The following is a description of a gene set: from publication He P, Lim K, Sun D, Pett JP, Jeng Q, Polanski K, Dong Z, Bolt L, Richardson L, Mamanova L, Dabrowska M, Wilbrey-Clark A, Madissoon E, Tuong ZK, Dann E, Suo C, Goh I, Yoshida M, Nikolić MZ, Janes SM, He X, Barker RA, Teichmann SA, Marioni JC, Meyer KB, Rawlins EL (PMID 36493756) Human Gene Set: HE_LIM_SUN_FETAL_LUNG_C5_CD5_POS_CCL22_POS_MATURE_B_CELL studied in species Homo sapiens CD5+ CCL22+ mature B, and this is the list of marker genes: RGS1, EML2, SCO2 (synthesis of cytochrome C oxidase 2), CASP3, MPEG1, NENF, LINC00926, ZBTB17, NUP37, ATP2A2, EMC1, CR2, ARMCX6, BSPRY, RASA4B, ILRUN, HUWE1, NAGK, CHKB, TNFRSF18, RSU1, QPCT, STAP1 (signal transducing adaptor family member 1), PFAS, PTGER4, CNR2, IFRD2, ZMYND11, VOPP1, ATP1A1, SH2B2, TNFRSF13C, COMTD1, PTGES2, TOR3A, AGPAT3, TRAF2, CENPH, PRKCD, BIN2, TRMT1, GPX7, STK38L, BCAR3, TOM1, GNL3, ORMDL2, TNFRSF13B, MRPL17, CXCR5, PNO1, RHEX, GRK3, GPATCH4, EHD4, MRPL27, PABPC4, ICMT, ABI3, RNF126, TOP6BL (NCBI Gene Id 79703), CARM1, NFKB2, CMSS1, C1orf50, TYMP, MTHFD2, IL2RG, FADD, PHF19, SLC37A1, KLF13, ANKRD26, BMP2K, GEN1, BOLA2, ABCF3, PAGR1, SLC29A1, TRAC, HSD17B4, PAPSS1, VARS2, CD44, DESI1, ARF3, BATF, RAB30, AGL, ADISSP (NCBI Gene Id 54976), ADAM19, MSMO1, NPM3, TPTEP2-CSNK1E, JOSD2, DCPS, ACADS, UROS, ARHGAP18, TLR10, MYO5A, NPIPB4 (NCBI Gene Id 440345), PCNX1, COL9A2, PAK1IP1, ASCC3, HILPDA, GNL2, MTLN, BLVRB, DEGS1, IFI30, HSDL2, NTHL1, BCAT2, ALDH18A1, ZYX, TFEB, PRKAR1B, GTF2H5, DPH6, RPP25, CALU, TRAPPC5, TIMMDC1, TBL2 (NCBI Gene Id 27203), LINC01857, S100A6, CD82, HDAC3, PPM1M, ENTPD1, CHMP4A, NXPE3, MRPL1, DIPK1A, WDR75, ST3GAL2, PARVB (parvin beta), POLR1C, CDKN2A, FAM162A, TRBC1, NUDT14, MCRIP2, ZCRB1, NET1, IL21R, NFKBIE, ALDH3A2 (aldehyde dehydrogenase 3 family member A2), LASP1, COPRS, SEL1L3, PPP1R9B, NCLN, GMDS, TXLNG, MTAP, ACY1, PLAGL1, MAP3K8, SGK1, RRP9, PDLIM7, HCST, JAZF1, HSPBP1, SMIM30, MS4A6A, MECR, AEN, RPA1, ADGRG5, ATIC, CCL4, CCND2, LTA, FH, SFXN4, SRD5A1, NANS, PELI1 (NCBI Gene Id 57334), ZNF490 (NCBI Gene Id 57474), CASP1, PIAS2, BIK, BCL2L11, ETFB, GNPTAB, CHID1, NDFIP1, WDR89, SRM, BRI3BP, CCR7 (NCBI Gene Id 1236), TMEM35B, TRAF3 (NCBI Gene Id 7187), ERG28, PTPN7, CHKA, LACTB2, C1GALT1C1, EEIG1, ITPK1, THEM4, AP1S3, SDHAF3, SH3BP1, NOPCHAP1, ICAM1, TARBP2, BCL2A1, NAPSA, TMEM42, NOP2, MPDU1, PMM2, UQCC2, RILPL2, PNOC, DSE, BHLHE40, HSD17B8, PAWR, NBPF10, MYO1E, SH3YL1, DPH5, TYW3, ETF1, MCM6, CDK4, ITGB7 (integrin subunit beta 7), COMMD10 (NCBI Gene Id 55955), INSIG1, PCBD1, ABCE1, SLC35B2, ERCC4, AMPD3, ECE1, CCDC88C, LMAN1, KBTBD8, SNX18, IL27RA, GMFB, MIR155HG, LINC01480, PDCL3, ADAM8, SLC30A7, TBC1D9B, MRPS25, CTSH, WDFY1, LINC00996, SAMSN1, EHD1, NT5DC1, RGCC, APOBEC3F, IMMP2L, DERL1, ZNF593, CKLF, SEC24D, PLGRKT, APOBEC3G, MCOLN2, ZNF480, EBNA1BP2, CLEC17A, BCL2, RMND1, FAM81A, IFNLR1, RAB8B, FBXO4, POLD2, CD5, WARS1, NUP210, KAT2A, TRADD, TXLNA, MAPKAPK2, KPTN, NFATC1, PDCD4-AS1, FCRL2, ADPRH, PRDX4, CBFA2T3, TUBG1, DENND5B, CD68, CYBB, RELB, MED23, CDC42EP3, EEF2K, BLTP1, ST14, MYBBP1A (MYB binding protein 1a), PHPT1, RGS10, TBC1D8, WASHC3, MTX1, IFNGR1, NCOA1, RNF121, NOLC1, NUDT4, RASSF2, IGF2BP3, MMAB (NCBI Gene Id 89909), SHISAL2A, SRGN, IGFLR1, LONRF1, PHTF1, SMIM27, POLR1E, RASSF5, GLS, PDPK1, DALRD3, MYC, ALKBH6, ARHGAP1, CHMP7, S100A11, BID, MPI, EYA3, LTBP3, TRUB2, NAGPA, DPH2 (diphthamide biosynthesis 2), CYTOR, CREB3L2, IGHG1 (immunoglobulin heavy constant gamma 1 (G1m marker)), PPCDC, CCL3, SFI1, TSEN15, NUP205, TADA1, INPP5B, NFKB1, TNFRSF10A, ARL4C, RAB11FIP1, FAM136A, PEX10, NR4A3, TP53I11, KNOP1, C15orf39, NAMPT, SLAMF7, KATNA1, INTS9, FLNA, SYNE2, MCM2, TICAM1, MTERF4, ZNF688, GMPPA, STAT1, PFKP, SUPT5H, RECQL5, IGHG2, NUDT2, PYCR3, ACAT1, WNT10A, SNX25, CCR10, MRPL35, LARP4B, DHRS13, TESPA1, FKBP5 (NCBI Gene Id 2289), ITGAL, KCNAB2, MRPS12, SMS, NME1, PTPN12, HMBS, ENTR1, MAP3K14, PCCB, IRF5, WAPL, GPR65, RRBP1, TFRC, BRIX1, ANAPC1, SESN3, SNRNP25, DENND1C, QDPR, TENT5C, ACOX3, ATP6V1C2, ETV6, FUNDC1, KDM2A, RUNX3, SNAPC2 (small nuclear RNA activating complex polypeptide 2), MOGS, NICOL1, PELP1, RRP1, ZNF589, GCHFR, SLC12A2-DT, KYNU, NDUFAF8, IL10RA, ANXA7, LRRK2, DNPH1, SEMA7A, GCA, CCL4L2, ZNFX1, LPIN1, IMPACT, PLEK, CCDC28B (coiled-coil domain containing 28B), TRAP1, POGLUT1, KLHL12, SLC1A4, GCN1, NIBAN1 (NCBI Gene Id 63911), CTSZ, CRYM, NFKBIZ, CISD2, PHLDB3, PAICS, TTC31, CRYZ, SLC25A19, PLEKHO1, POLR3E, RAB29, RBM47, DYRK4, PUM3, DOK2, NAB2, SLC25A13, KLF4, DPP3, GBA1, TRMT61A, CD1D, TBC1D9, MIF4GD, OGT, PKIG, PMPCA, SLC25A45, POLR1F, CEPT1, LILRB4, PLK3, EBI3, ARPC4, DOHH, CD58, TESC, CINP, VARS1, ZNF7, IL6R, GLT8D1, MRTO4 (NCBI Gene Id 94394), TMEM14A, CHD3, MCCC2, RARA, EXOSC7, ARHGAP9, MRPL24, MDN1, NLE1, U2AF1L4, ECPAS, CCL22, ABCA6, DTNB, HEATR5B, TYK2, TCTN3 (NCBI Gene Id 26123), SLC5A6, CEBPB, MRPL11, TOP1MT, TMEM154, GGA1, ALKBH2, QTRT1, GNPDA1, SLC7A7, CTU2, CFLAR, RPIA, ECHDC2, DCTD, RHOF, SNX9, CFAP97, GM2A, TOLLIP, SERPINB9, ADTRP, SEC11C, S100A13 (NCBI Gene Id 6284), NEDD9, WDR43, CUL4B, CDIP1, WAC-AS1, AFTPH, EIF4G1, SREBF2, IVD, TTN, RASA4, JADE2, SNX8, TCIRG1, NFAT5, DUS2, LCK, HDAC9, MPHOSPH6, JAK2, MATK, CCDC86, COMMD1, POC1B, AKNA, ZDHHC12, CLECL1P, ZC3H12A, FBXW8, CTSC, PASK, EXOSC4, ELP3, ARHGAP24, NIPSNAP1, NOP16, S100A4, IFI27L2, BOP1, MYO3A, KCNN4, METTL8, MTFP1, UQCC5, C17orf49, NUFIP1, ALG2, MAPK13, HMOX2, DUSP23, DLD, XPNPEP3, ATG4C, GSTZ1, OMA1, UNG, LGMN, ACP5 (acid phosphatase 5, tartrate resistant), TSR3, UGCG, HPS5, CD1C, TGFB1, ADAMTS6, CISD1, POLD3, FCRL5, ORAI1, NOC3L, SPOPL, NCOA7, PDCD11, SEH1L, PDLIM2, ISOC2, RFTN1, LCMT1, UTP4, DHRS4, BOLA3, ZNF880, CCDC141, SCYL2, WDR4, MRPL15, ENOSF1, SIGLEC10, GBF1, ABHD6, PPP2R5A, STAMBPL1, OTUD5, EVI2A, MRNIP, PTPN22, NCOR2, RRAS2, ELF4, APOBEC3C, SPATA20, PNPLA6, FMNL3, C12orf42, GGCT, RNASE6, CCDC47, MDFIC, P2RY14, CD27, PCK2, IGHG3, PARN, RHPN1, SNX11, NRG4, SIGMAR1, TNFAIP8L1, ELK1, LPCAT1, RRP15, ZNF827 (zinc finger protein 827), SKAP1, GNG8, RHOC, POLR3K, SNX10, HTT, MVP, SLX9, S100A10 (NCBI Gene Id 6281), HDHD5, PRKD3 (NCBI Gene Id 23683), CMTM3 (CKLF like MARVEL transmembrane domain containing 3), TANK, SUMF2, PES1, MRRF